Given this list of marker genes KAT2A, MICOS13, TAF8, BTRC, PPP1R12B, ZW10, SPEF1, PSENEN, PRCC, BANP, CDC6, BUB1B, NKIRAS1 (NCBI Gene Id 57083), ENKD1, MED11, MACC1, SKP2, PLEKHB1, MINDY1, EXO1, NCOA3, CLDND1 (claudin domain containing 1), UBXN8, SLC25A27, ZNF471, RPL15, TBC1D8B, SLC38A9, RPS27A, UQCR10, HSP90B1, KCNE4, CERT1, ARV1, MUS81, KBTBD8, SNW1, UBALD1 (NCBI Gene Id 124402), TMEM258, HCFC1R1, NAPB, SWT1, LRTOMT, VKORC1, ITCH (itchy E3 ubiquitin protein ligase), ZNF420, DYNC1H1, CYB561D2, RAB8B, WDFY2, SETMAR, U2AF1L4, ZNF570, ZNFX1, HACE1, ZNF416, NUP153, RDH14, TRIM23, SDCCAG8, PA2G4, ZNF235, BRMS1L, TLE4, TOGARAM1, BIVM, RNF121, SHMT2, PNKD, TMEM214, DQX1, FKBP4, APBA3, ZNF485, HSD11B1L (hydroxysteroid 11-beta dehydrogenase 1 like), FMC1, PCM1, SERTAD3, ZNF354C, SNX16, CCDC25, ZFP2, RPL6, RPP21, NDC1, RABAC1, TMEM245, RALBP1, PPP1R7, PDCD10, SYT3, ZNF691 (zinc finger protein 691), GPD1L, SNX17, AAMP, VPS41, PABPC1, ZNF568, AHCTF1, INO80E, MYL6B, KLHL28, ARID5A, RBL2, AAK1, CDC45, SH3BGRL2, PDIA5, ZNF875, CAPN15, PSMD11, NUDT13, CNPY2, ZNF24, TNPO2, NCLN, ZNF233, UBE2N, BCKDK, AZI2, VPS50, GSK3A, RRAS (NCBI Gene Id 6237), ADAM22, ITSN1, SIRT2, ZNF446, COQ10A, ZNF286A, AP2S1, USP5, SESN1, TMEM102, PHF13, TP53, UBQLN4, SAMD12, ETFDH, CNTD1, OPHN1, NFXL1, SMARCAL1, UBE2H, ZDHHC14, ABCC5, RABL3, IFTAP, UFSP2, MAP2K6, RAD51B, POLR1G, CIAO1, FBXO9, HSPA13, TRUB1, CCDC191, RANGAP1, NTHL1, NUMA1, DNAJC18, RDH10, WBP2, BABAM1, KCNN3, ZNF513, MRPL54, CEP97 (centrosomal protein 97), TTLL4, WRAP53, FNTB, SLC29A2, BET1, ING3, MPI, NOS3, ZNF189, TMEM127, IQGAP3, R3HDM1, HDAC8, RDH11 (retinol dehydrogenase 11), PANK3, ATXN7L2, UTP11, SPC25, WRN, FANCG, EHMT2, PRMT5, IZUMO1, CDC25A, TRPC4AP, ANKRD13B, POLR1B, TTBK2 (tau tubulin kinase 2), INVS, ZNF180, KLHL24 (NCBI Gene Id 79965), C19orf44, HIKESHI, RPIA, R3HCC1L, COMMD9, TRIP10, TBX6, STMN1, PRPF19, PLEKHA1, ZNF75D, VPS45, RIDA, RPP40, ESPL1, PPRC1, DNAJC28, FIS1, HSD17B4, VTI1B, PPP2R5B, CDK9, ZNF451, PCYT2, SESN2, CLINT1, WASF1, ALKBH8, SCAMP3, CYP39A1, TMEM208, DPM3, ZSWIM9, ZC4H2, MTR, JARID2, RBM41, SGF29, ADO, FEN1, CBLL1, UBL3, SPCS2, HEXIM2, TIAL1, CCDC150, PRUNE1, CSDE1, KMT2D, PRMT6, EMSY, SMCR8, LAMTOR2, FKBPL, CCDC126, CDCA3, DCTN2, MRPL34, EIF2B4 (eukaryotic translation initiation factor 2B subunit delta), PHF12, ORMDL3, AP2M1, IMMT, PACC1, FGFR1, PPP4R3B, RNASEH2C, CLHC1, NBR2, MARCHF5, ZFP1, HTN1, SLC38A7, NUDT12, ZFYVE1 (NCBI Gene Id 57694), GRK4, WNK1, PPARGC1A, HMBOX1, DNAJC17, TMOD3, IPO7, ZNF419, CALCOCO1, FUZ, KATNAL1, SGSM3, MAX, TOP3A, DNM1L, PTDSS2 (NCBI Gene Id 81490), GDAP1, ELP6, FTSJ1, DERL1, ENOX2, TSC2, THOC6, ITPR1, LARS1, BRD8, PURG (NCBI Gene Id 29942), PNPLA6 (patatin like phospholipase domain containing 6), CMAS, IPO13, CLP1, ZNF274, HSPB9, LIG1, PGM2L1, SFXN5, NMT1, BOD1, MAF1, SLC35B4, DCUN1D4, ZFYVE19, DPYSL5, MRPL19 (mitochondrial ribosomal protein L19), UFD1, SUFU, DCAKD, DTX2, C14orf178, SHARPIN, NPRL2, COA3, SERPINI1, COX7C, POP1, MRPL42, CPEB3, SH2D6, PPP6C, CALR3, BUB3, CRYZL1, CIAO2A, POGLUT2, MITF, LRWD1, TIMM21, DMXL1, ZCCHC7, BOLA1, CA11, ACBD5, NTAN1, ACTR1A, SHKBP1, ZNF449, TRMT1L, PAFAH2, CTIF, TFAP4, UBR2, RNASEH2A, C6orf62, RAB1B, FBXL9P, YWHAG, WDTC1, ZNF569, PRKN, PACRG, ABLIM2, BACE1, ASXL1, LGMN, HSCB, APH1A, CRTC2, ATF6B, CTF1, NFATC2IP, SND1 (staphylococcal nuclease and tudor domain containing 1), USP48, MZF1, RPS11, RSBN1, HBP1, NR1D1, MFN2, RDH12, RPL7, FBXO15, COX7B, RNF10, STAU1, PROSER3, ZNF571, SMUG1, C12orf43, POLK, FDPS, ADCK1, DUS3L, TRAPPC13, MSL3, SNX1, MRPL50, MON1A, ZCCHC8, SMIM11, TMED5, MVB12A, CFL1, PSMC4, HMG20A, HIRIP3, GRWD1, ATP6V1F (ATPase H+ transporting V1 subunit F), PDE6D, QTRT2, SRSF2, CDC40, RAB5C, ASXL2, TMEM160, THAP11, RPS6KB2, BRCA1, TXLNG, NFKBIB, DNAJC12, ZFP28, DNAJB12, ATL3, TMEM150A, RAB30, PUS3, MDH1 (malate dehydrogenase 1), NUDCD1, MAP3K10, LCMT1, DYNC1I2, DHX30, PLPP7, CDC26, RAB3C, TTC13, ZNF546, ZNF8, FOXO4, IRF2BP1, STXBP5, FBXW11, ALKBH4, CHMP4B, UPF3B, PRPF4, HSPB6 (NCBI Gene Id 126393), INTS9, ZNF112, CCDC90B, HSPH1, ADSS2, DDX25, ATP13A2, PRIM1 (NCBI Gene Id 5557), DFFA, PASK, GATB, M6PR (NCBI Gene Id 4074), FAM78A, here is a description of the gene set: Human Gene Set: ACTAYRNNNCCCR_UNKNOWN Comprehensive identification of all functional elements encoded in the human genome is a fundamental need in biomedical research. Here, we present a comparative analysis of the human, mouse, rat and dog genomes to create a systematic catalogue of common regulatory motifs in promoters and 3' untranslated regions (3' UTRs). The promoter analysis yields 174 candidate motifs, including most previously known transcription-factor binding sites and 105 new motifs. The 3'-UTR analysis yields 106 motifs likely to be involved in post-transcriptional regulation. Nearly one-half are associated with microRNAs (miRNAs), leading to the discovery of many new miRNA genes and their likely target genes. Our results suggest that previous estimates of the number of human miRNA genes were low, and that miRNAs regulate at least 20% of human genes. The overall results provide a systematic view of gene regulation in the human, which will be refined as additional mammalian genomes become available. Genes having at least one occurrence of the highly conserved motif M4 ACTAYRNNNCCCR in the regions spanning 4 kb centered on their transcription starting sites. The motif does not match any known transcription factor binding site. from publication Xie X, Lu J, Kulbokas EJ, Golub TR, Mootha V, Lindblad-Toh K, Lander ES, Kellis M (PMID 15735639) studied in species Homo sapiens